The following is a description of a gene set: Calcineurin activates NFAT species: Homo sapiens Human Gene Set: REACTOME_CALCINEURIN_ACTIVATES_NFAT, and this is the list of marker genes: NFATC3, NFATC1, PPIA, FKBP1A, PPP3CA, PPP3CB, NFATC2, PPP3R1, CALM1